Given this list of marker genes Tsku, Tshr, Atp2b2, Ripor2 (RHO family interacting cell polarization regulator 2), Strc, Otog, Alms1, Pdzd7, Pcdh15, Myo3a, Vangl2, Clrn1, Adgrv1, Sec24b, Kif3a, Hey1, Nherf1, Clic5, Otogl, Ift27, Clrn2, Ift88, Ush1g, Myo3b, Lhfpl5, Grxcr1, Grxcr2, Trip11, Ift20, Myo7a, Ankrd24, Whrn, Mks1, Sod1, Hes1, Ttc8, Cthrc1, Pls1, Minar2, Tecta (NCBI Gene Id 270149), Ush1c, Scrib, Tprn, Cecr2, Pjvk, Rest, Fat4, Elmod3, Sdc4, Triobp, Cdh23, Hes5, here is a description of the gene set: Mouse Gene Set: GOBP_INNER_EAR_RECEPTOR_CELL_STEREOCILIUM_ORGANIZATION A process that is carried out at the cellular level which results in the assembly, arrangement of constituent parts, or disassembly of a stereocilium. A stereocilium is an actin-based protrusion from the apical surface of inner ear receptor cells. studied in species Mus musculus